Given this list of marker genes NFKBIA, UBR5, RBM22, SMAD3, APOD, SUFU, CWH43, HSP90AA1, GLI3, MDFIC, NUP58 (nucleoporin 58), CD36, UFM1, JUP, HYAL2, ZC3H12A, SMO, JAK2, EFCAB7, FLNA, CHP1, CDK1, IFNG, CHP2, HCLS1, ANGPT1, EPM2A, EI24, CABP1, DMAP1, TRIM28, CDH1, PRKD1, SIRT6, TARDBP, NF1, SUMO1, TPR, HDAC3, IPO5, YWHAB, RAB23, ZIC1, TGFB1, MAPK14, PRKCD, ECT2, MAVS, PSEN1, BMP4, XBP1, PIK3R2, ZPR1, FERMT1, PKIG, RAN, PIK3R1, SHH, PKIA, BAG3, LEP, EP300, here is a description of the gene set: Any process that modulates the frequency, rate or extent of movement of proteins from the cytoplasm to the nucleus. Human Gene Set: GOBP_REGULATION_OF_PROTEIN_IMPORT_INTO_NUCLEUS species: Homo sapiens